The following is a description of a gene set: electronically inferred by orthology from the curated human pathway part of: Mitotic Prometaphase This event has been computationally inferred from an event that has been demonstrated in another species.<p>The inference is based on the homology mapping from PANTHER. Briefly, reactions for which all involved PhysicalEntities (in input, output and catalyst) have a mapped orthologue/paralogue (for complexes at least 75% of components must have a mapping) are inferred to the other species. species: Mus musculus Reactome Pathway: Recruitment of NuMA to mitotic centrosomes, and this is the list of marker genes: Cep72, Nde1, Mzt1, Cenpj, Sfi1, Haus8, Csnk1e, Tuba1b, Prkar2b, Tubb4b, Cep192, Cep41, Prkaca, Tuba8, Cep57, Haus5, Ywhae, Tuba1a, Ninl, Dctn1, Actr1a, Cep63, Clasp1, Tubb4a, Tubgcp6 (NCBI Gene Id 328580), Tubal3, Tuba1c, Cep290, Cdk1, Sdccag8, Nedd1, Tubb6, Haus1, Cep152 (NCBI Gene Id 99100), Dynll1, Cep135, Cep131, Tuba4a, Tubgcp2, Plk1, Tubb2b (tubulin, beta 2B class IIB), Tuba3b, Tubgcp3, Haus7, Cep43